The following is a description of a gene set: from publication Ventre E, Brinza L, Schicklin S, Mafille J, Coupet CA, Marçais A, Djebali S, Jubin V, Walzer T, Marvel J (PMID 22942430) Genes down-regulated in comparison of memory CD8 T cells treated with IL7 versus those treated with IL4. studied in species Homo sapiens Human Gene Set: GSE32423_IL7_VS_IL4_MEMORY_CD8_TCELL_DN Effects of IL-4 on CD8 T cells functions are largely unknown. IL-4 induces survival and proliferation of CD8 T cells, but several studies suggest that IL-4 could also affect several functions of CD8 T cells such as cytotoxicity. Our team has shown that IL-4 repress the expression of Ccl5 in vitro. To define more precisely the impact of IL-4 on CD8 T cells, we performed a whole genome expression microarray analysis of naive and memory CD8 T cells cultured in presence or absence of IL-4. This approach allowed us to define the IL4-gene-expression signature on CD8 T cells., and this is the list of marker genes: UPB1, RBMS1, IDNK, COL10A1, TOR2A, SMC1A, PLBD1, C19orf47, JAK3, C4B (complement C4B (Chido/Rodgers blood group)), AGTRAP, SDR42E1, PPM1L, SHF, UQCRQ, ZHX3, HLA-DQA1, AFG2B, TGIF2, CNP, PAM16, NCBP1, EIF2S3, TNNI3, SETD1A, ZMAT2, COPA, KCNS3, TVP23A, CNDP2, SRGAP3, MTIF3, DBNL, PHF5A, NTAN1, SAYSD1, GABARAPL2, RIPK3, CMKLR1, TRIM26, SHOX2, TMEM143, DNLZ, IKZF3, PSMB3, LARP1, GEMIN5 (NCBI Gene Id 25929), DHX58, RBKS, CLU, DERA, LGALS3BP, TMEM40, UFC1, PGK2, PCDH17, G0S2, SLC9A6, SAR1B, ENSA, AIMP2, SLFN13, METTL9, RRP7A, CCDC22, MYRIP, GHR, MRPL17, PSME1, MCTS1, TAMM41, TNFAIP3, NCAPG2, MRPL36, VCAM1, ATP5PO, MRPS25, RNPEP, SLC6A5, SLC25A34, XPNPEP1, MAP3K8, CHURC1, CHCHD10 (coiled-coil-helix-coiled-coil-helix domain containing 10), STAMBP, CIB1, MRPS26, SMARCE1, SNAI3-AS1, RAB19, PRKD3, NUDT1, ARHGEF28, DAXX (NCBI Gene Id 1616), DMRTC2, MYBPC1, KLHL11, PSRC1, NDST1, NDUFB4, MRPS34, TULP3, RAB13, DHODH, ST6GALNAC5, SPRR2A, MAP7D2, TMEM104, PRPF31, CCR10, FYB1, TRIM27, SARS1, SNF8, PIH1D1, TMEM140, AVEN, TMEM234, RBP1, CEND1, ILF2, DENND5A, EIF1AD, GGT5, IFIT1B, LDLR, RGS1, MDGA1, HSD3B7, TEFM, IRF4, PCSK9, DLK1, GLIPR2, PSMD14, NFYC, APMAP, NFIL3, PKN3, PCGF2, GPATCH2L, SSRP1, C21orf91, SZRD1, GBP6, ZFHX3, PSPH, C3orf38, CA7, KRTAP26-1 (NCBI Gene Id 388818), LRRC2, DMKN, KBTBD4, LCP1, FAM219B, SNRPA, MRPL12, NUP107, BATF3, DCTN5, NTPCR, RAP1GDS1, ATG9A, SUSD3, PSMD9, MAP6, DUSP11, CCDC77, MCL1, FLYWCH2, PINX1, CDH5, NUMB, ATP5MF (ATP synthase membrane subunit f), DDC, PIGS, INPP4B, COX14, ADH4, NME1, HSPD1, PFKM, SUV39H1, TGFBR3, COX8A, SHISAL2B, ELF1, NAA40, FAM156A, BOLA3 (NCBI Gene Id 388962), PKNOX2, SLIRP, RASGRP1, RIPK1, OR4C3, KLK6, PLP2, PPP3CC, ACOX3, SMAD5